Given this list of marker genes ATP1B1, UMOD, FLOT2, CAV1, MYADM, here is a description of the gene set: species: Homo sapiens Human Gene Set: GOBP_PROTEIN_LOCALIZATION_TO_PLASMA_MEMBRANE_RAFT A process in which a protein is transported to, or maintained in, a location within a plasma membrane raft.